The following is a description of a gene set: species: Homo sapiens Wnt signaling modulation, SOST/LRP4. Pathway ID: N01441. Pathway type: Reference. Pathway class: nt06505 WNT signaling. Pathway Definition from KEGG: (SOST+LRP4) -| (FZD+LRP5/6) Human Gene Set: KEGG_MEDICUS_REFERENCE_WNT_SIGNALING_MODULATION_SOST_LRP4, and this is the list of marker genes: FZD4 (frizzled class receptor 4), FZD8, LRP4, LRP6, LRP5, SOST, FZD3, FZD2, FZD6, FZD7, FZD9, FZD5, FZD10, FZD1